The following is a description of a gene set: from publication Ouyang W, Beckett O, Ma Q, Paik JH, DePinho RA, Li MO (PMID 20467422) Genes down-regulated in T reg cells: wildtype versus FOXO1 and FOXO3. Identification of Foxos target genes in Treg cells. Foxo1and Foxo3 are transcription factors of Foxo family. CD4+Foxp3+ Treg cells isolated from wild-type and Foxo1/3-deficient mice were analyzed by global gene expression profiling. Results indicate Foxos regulate expression of a subset of Treg cell signature genes and genes in control of T cell homeostasis, signaling and metabolism. Human Gene Set: GSE21678_WT_VS_FOXO1_FOXO3_KO_TREG_DN species: Homo sapiens, and this is the list of marker genes: FAM223B, C10orf95, ZNF224, WDR41, MTHFD1L, IFT22, ZFP69B, FANCE, MAP1S, AGMAT, AP5S1, NIPSNAP1, RCC1, TBRG4 (NCBI Gene Id 9238), RING1, TARP, PKNOX1, COQ4, SCRN2, NUDT7, DPH2, SPMIP6, TUBA1A (tubulin alpha 1a), TRIB3, ARMCX1, BCL11A, L3MBTL2 (L3MBTL histone methyl-lysine binding protein 2), SURF2, MSH6, TCP10L3, LARS2, ZBTB9, PEX10, ENTR1, CCDC22, MID1, TMEM229B, GART, PHGDH, HSD17B6, ST3GAL2, PLS1, SIRT4, ZNF284, PGBD2, DNAJC16, HGH1, WDR77, CD99L2, TIMM13, LETM1, PFAS, OCEL1, VAT1, SALL2, ATP13A2, B3GALT4, MRPL45, TMEM143, GIMAP5, SCYL1, PDK2, GAL3ST4, TWNK, PRKAG2-AS1, FNTB, ZNF235, DMAC2, EARS2, POMGNT2, ZSWIM8, ZNHIT2, FARSA, UBIAD1, PARS2, RUNDC3B, TCTN3, LHPP, ZNF343, BYSL, ABCF2, ALKBH2, DCAF4, CSTPP1, RAB15, ZSCAN26, TRPT1, ROBO1, CPA5, PAFAH1B3, RRP9, HYLS1, FXYD6, PXMP2, CHID1, PPEF1, NR2C2AP, TMEM161A, MTUS1, PTH, OR52K3P, CCDC102A, ABCB1, NIPSNAP3B, ELP6, SGCA, FAM86B1, NBEA, ZNF19, KDM4A, GTSF1, RNF185, INTS5, RFESD, NHEJ1, ZNF511, ZNF71, MMP25, MAGED2, CXCL11, IKBKE, AKAP12, MYO9A, EEFSEC, TMEM256, SLC2A1, AIMP2, MYC, LIN9, PPAN, RAD51D, PSAT1, ATXN7L3, BRF2, ERVV-1, CBR3 (carbonyl reductase 3), RTL10, TM7SF2, SENP8, IPO4, FAM50B, ZNF514, DTHD1, ZKSCAN4 (zinc finger with KRAB and SCAN domains 4), RPE, KRBA2, ZFTRAF1, PDCD11, ZNF239, KLB, LFNG, PDCD5, ISOC2, TMEM129, SMIM8, BEND5, POLR1G, ARMCX2, REXO4, CHAF1A, MBOAT7, SRF, FCGBP, UNC13C, EIF2B3, KCNK9, MIPEP, ZFTA, NCOA5, ZW10, ZNF671, ENDOG, LZTS2, RITA1, TRIM32, ANXA2P3, PWP2, MSX2, CCR2, STXBP4, DDX51, AKAP1, BCDIN3D, PFDN6, DOLK, DHCR24, PHRF1, TCEA2, SLC9A3-AS1 (SLC9A3 antisense RNA 1), CCDC7, MAGEB2, HNRNPF